Given this list of marker genes Trak1, Mgarp, Sybu, Hdac6, Hif1a, Spast, Nefl, Fez1, Hsbp1, Armcx3, Agtpbp1, Agbl4, Uchl1, Actr10, Map6, here is a description of the gene set: Mouse Gene Set: GOBP_AXONAL_TRANSPORT_OF_MITOCHONDRION The directed movement of mitochondria along microtubules in nerve cell axons. species: Mus musculus